The following is a description of a gene set: Human Gene Set: GOCC_ALVEOLAR_LAMELLAR_BODY species: Homo sapiens A specialized secretory organelle found in type II pneumocytes and involved in the synthesis, secretion, and reutilization of pulmonary surfactant., and this is the list of marker genes: CTSH, NAPSA, ABCA3, SFTPB, SFTPC, LAMP3, RAB7A, TMEM63B